The following is a description of a gene set: Human Gene Set: GOBP_INTESTINAL_EPITHELIAL_STRUCTURE_MAINTENANCE A tissue homeostatic process required for the maintenance of the structure of the intestinal epithelium. studied in species Homo sapiens, and this is the list of marker genes: IL10RA, NEUROD1, IL17A, SOX9, NR1I2, ZNF830, TLR4, INAVA, SLC22A5